Given this list of marker genes SUN5, LBR, MECP2, SHH, TRIP13, BUB1B, NKX2-5, CDAN1, SEC23B, PMFBP1, RAI1, ESCO2, TSC1, GJA1, here is a description of the gene set: Human Gene Set: HP_ABNORMALITY_OF_CHROMOSOME_SEGREGATION species: Homo sapiens Abnormality of chromosome segregation An abnormality of chromosome segregation.